Given this list of marker genes HLA-DRB1, IRF2, NOD2, TLR4, TLR7, HLA-DRB3, HLA-DRB4, CD86, TLR6, HLA-DRA, IRF9, STAT1, HLA-DRB5, TLR1, TLR8, TLR2, IRF7, TAP1, IRF1, CD40, MYD88, here is a description of the gene set: Human Gene Set: SOBOLEV_PBMC_PANDEMRIX_AGE_18_64YO_1DY_UP studied in species Homo sapiens Genes up-regulated in peripheral blood mononuclear cell 1d vs 0d in adults (18-64) after exposure to Pandemrix, time point 1D Adjuvanted vaccines afford invaluable protection against disease, and the molecular and cellular changes they induce offer direct insight into human immunobiology. Here we show that within 24 h of receiving adjuvanted swine flu vaccine, healthy individuals made expansive, complex molecular and cellular responses that included overt lymphoid as well as myeloid contributions. Unexpectedly, this early response was subtly but significantly different in people older than ~35 years. Wide-ranging adverse clinical events can seriously confound vaccine adoption, but whether there are immunological correlates of these is unknown. Here we identify a molecular signature of adverse events that was commonly associated with an existing B cell phenotype. Thus immunophenotypic variation among healthy humans may be manifest in complex pathophysiological responses. from publication Sobolev O, Binda E, O'Farrell S, Lorenc A, Pradines J, Huang Y, Duffner J, Schulz R, Cason J, Zambon M, Malim MH, Peakman M, Cope A, Capila I, Kaundinya GV, Hayday AC (PMID 26726811)